Given this list of marker genes Guca2b, Ins2, Gucy2e, Cgas, Nppb, Ins1, Aqp1 (aquaporin 1), Prkg1, Kcnc2, Gucy1a1, Nherf4, Ednrb, Htr2b, Gucy2d, Nppa, Mtnr1b, Adnp, Nos2, Npr2, Rundc3a, Agtr2, Apoe, Gucy1b1, Pde10a, Irag1, Htr2c, Nppc, Adora2b, Pde2a, Nos1, Pde11a, Thbs1, Guca1a, Gucy1a2 (NCBI Gene Id 70710), Gucy2f, Atp2b4, Gucy1b2, Kdr, Npr1, Pde3a, Cd36, here is a description of the gene set: Mouse Gene Set: GOBP_CGMP_MEDIATED_SIGNALING studied in species Mus musculus An intracellular signaling cassette that starts with production of cyclic GMP (cGMP), and ends with activation of downstream effectors that further transmit the signal within the cell.